The following is a description of a gene set: Mouse Gene Set: GOCC_SAGA_COMPLEX studied in species Mus musculus A SAGA-type histone acetyltransferase complex that deubiquitinates H2A and/or H2B. This complex is organized into several functional submodules: a structural core including the activator binding module and consisting of ADA1 or a homolog, members of the SPT and TAF protein families as well as promotor recruitment factor TRRAP/TRA1, a histone acetyltransferase (HAT) module consisting of GCN5/KAT2A or PCAF/KAT2B, ADA2, ADA3/NGG1, and SGF29 or homologues thereof, a histone deubiquitinase (DUB) module consisting of ATXN7/SGF73, ATXN7L3/SGF11, ENY2/SUS1 and USP22/UBP8 or homologues thereof, and in some taxa a splicing module consisting of SF3B3 and SF3B5 or homologues thereof (not in fungi). In budding yeast also contains Spt8 which distinguishes it from SAGA-like (SLIK) complex ., and this is the list of marker genes: Supt7l, Tada1, Kat2a, Tada2b, Tada3, Supt20, Sf3b3 (NCBI Gene Id 70506), Atxn7 (ataxin 7), Taf5l, Atxn7l3, Taf12, Taf10, Taf5, Taf6l, Usp22, Tada2a, Trrap (NCBI Gene Id 640386), Supt3, Taf9, Eny2, Kat2b, Taf6, Sgf29, Sf3b5